Given this list of marker genes DVL3, DVL1, NOX1, FZD7, JUN, NOXA1 (NADPH oxidase activator 1), DVL2, WNT5A, CYBA, MAPK8, NOXO1, RAC1, here is a description of the gene set: Killing mechanisms studied in species Homo sapiens Human Gene Set: REACTOME_KILLING_MECHANISMS